The following is a description of a gene set: Mouse Gene Set: CUI_T_CELL_CD4_DECORIN_RESPONSE_DN studied in species Mus musculus from publication Cui A, Huang T, Li S, Ma A, Pérez JL, Sander C, Keskin DB, Wu CJ, Fraenkel E, Hacohen N (PMID 38057668) Cytokines mediate cell-cell communication in the immune system and represent important therapeutic targets. A myriad of studies have highlighted their central role in immune function, yet we lack a global view of the cellular responses of each immune cell type to each cytokine. To address this gap, the authors created the Immune Dictionary, a compendium of single-cell transcriptomic profiles of more than 17 immune cell types in response to each of 86 cytokines (>1,400 cytokine-cell type combinations) in mouse lymph nodes in vivo. A cytokine-centric view of the dictionary revealed that most cytokines induce highly cell-type-specific responses. For example, the inflammatory cytokine interleukin-1β induces distinct gene programmes in almost every cell type. A cell-type-centric view of the dictionary identified more than 66 cytokine-driven cellular polarization states across immune cell types, including previously uncharacterized states such as an interleukin-18-induced polyfunctional natural killer cell state. Genes negatively differentially expressed in cell type: CD4+ T cell upon treatment with cytokine: Decorin in mouse lymph nodes in vivo., and this is the list of marker genes: Hspa8, Klf6, Tsc22d3, Junb, Dnajb1 (NCBI Gene Id 81489)